Given this list of marker genes FEN1, GAS5, NOCT, RCN2, EIF1AY, UBA3, HMGB3, RBBP6, VBP1, TXNRD1, PTDSS1 (phosphatidylserine synthase 1), EIF4A2, NQO1, SNORD22, CYB5A, SPIN1, RAB18, DCK (deoxycytidine kinase), ACTG1, MARK2, CXCR4, CDC6, PELI1, XBP1, LYPLA1, LMO4, SP3, RBBP7, ATP6V1A, HNRNPDL (NCBI Gene Id 9987), PGRMC1, VPS4B, RRM2 (ribonucleotide reductase regulatory subunit M2), PLK4, PRKAR1A (protein kinase cAMP-dependent type I regulatory subunit alpha), PSMA3, here is a description of the gene set: Up-regulated at 4 hours following treatment of mouse lymphocytes (TK 3.7.2C) with a high dose of methyl methanesulfonate (MMS) Exposure to DNA-damaging agents can elicit a variety of stress-related responses that may alter the gene expression of numerous biological pathways. We used Affymetrix microarrays to detect gene expression changes in mouse lymphoma (L5178Y) and human lymphoblastoid (TK6) cells in response to methyl methanesulfonate (MMS; a prototypical alkylating agent) and bleomycin (a prototypical oxidative mutagen). Cells were treated for 4 hr, and RNA was isolated either at the end of the treatment or after a 20-hr recovery period. Two concentrations of each agent were used based on cytotoxicity levels and Tk mutant frequencies. Our microarray data analysis indicated that MMS and bleomycin gene expression responses were considerably different in mouse cells versus human cells. The results also suggested that more comprehensive cellular responses to MMS and bleomycin occurred in TK6 cells than in L5178Y cells. In contrast to L5178Y cells, the response of TK6 cells to MMS and bleomycin was characterized by the induction of p53-dependent genes that are involved in DNA repair, cell cycle regulation, and apoptosis. It appears that the induction of DNA damage by MMS in human TK6 cells mediated cytotoxicity and led to decreased cell survival. This may explain the greater sensitivity of TK6 cells to cytotoxic effects of MMS compared to L5178Y cells. Bleomycin exerted comparable cytotoxic effects in the two cell lines. Overall, these studies were unable to identify distinctive gene expression changes that differentiated bleomycin from MMS in either TK6 cells or mouse lymphoma cells. species: Homo sapiens from publication Islaih M, Li B, Kadura IA, Reid-Hubbard JL, Deahl JT, Altizer JL, Watson DE, Newton RK (PMID 15515172) Human Gene Set: MMS_MOUSE_LYMPH_HIGH_4HRS_UP